The following is a description of a gene set: Mouse Gene Set: GOBP_PRESYNAPSE_ASSEMBLY The aggregation, arrangement and bonding together of a set of components to form a presynapse. species: Mus musculus, and this is the list of marker genes: Il1rapl1, Cntn5, Slitrk1, Eif4g1, Ntng2, Slitrk3 (SLIT and NTRK-like family, member 3), Wnt3a, Pclo, Sdcbp, App, Il1rap, Efnb3, Bsn, Wnt7a, Farp1, Slitrk2, Lrp4, Ptprd, Cadm1, Fzd1, Dkk1, Lrfn3, Ntrk3, Nlgn3, Nlgn4l, Mdga1, Dvl1, Ptprs, Arf6, Grid2, Snca, Igsf11, Lrrc4b, Clstn3, Lrrtm1, Pten, Nrxn1, Pcdh17, Lrfn5, Gpc4, Nlgn1, Mdga2, Fzd5, Cbln1, Lrrtm3, Nlgn2, Efnb1 (ephrin B1), Nrg1, Efnb2, Lrfn4, Il1rapl2